The following is a description of a gene set: species: Homo sapiens from publication He P, Lim K, Sun D, Pett JP, Jeng Q, Polanski K, Dong Z, Bolt L, Richardson L, Mamanova L, Dabrowska M, Wilbrey-Clark A, Madissoon E, Tuong ZK, Dann E, Suo C, Goh I, Yoshida M, Nikolić MZ, Janes SM, He X, Barker RA, Teichmann SA, Marioni JC, Meyer KB, Rawlins EL (PMID 36493756) Human Gene Set: HE_LIM_SUN_FETAL_LUNG_C2_MEGAKARYOCYTE Megakaryocyte, and this is the list of marker genes: UNC45A, STRN4, IGF2BP2, LRRC8B, CLIC4, TMEM41A, CYB5R1, SLC35D1 (solute carrier family 35 member D1), RAB38, GSE1, ABLIM1 (actin binding LIM protein 1), AP5S1, PRKAA1, FRMD3, CST7, TUBGCP4, ING5, NBEAL2, AATK, KLHL5, KIAA0232, UNC13D, HEMGN, VPS37B, GP6, SERPINH1, SMIM3 (NCBI Gene Id 85027), APPL2 (NCBI Gene Id 55198), BANK1, SERPINE2 (NCBI Gene Id 5270), SLC22A17 (solute carrier family 22 member 17), SLC37A1, MSANTD3, GET1, ATP2A3, SNCA, FURIN, MAD2L1BP, IFI27L1, C11orf21, ZBTB16, TAL1, SACM1L, TUBA4A, MAFG, PPM1A, EPOR, PNMA1, RTN2, NFIB, EMILIN1, KIFC3, GTF3C5, EGF, MINDY1, MLC1, CD226, WASF1, ESAM, SMTN, ARHGAP6, TLK1 (NCBI Gene Id 9874), GFOD1, DGKI, GRK4, INPP5B, PELO, IGF1R, HPGD, ALAD (aminolevulinate dehydratase), SIRT3 (NCBI Gene Id 23410), PDE3A, LYPLAL1, ARMC8, PGM1, DENND4C, TREML1, AGBL5, DGKD, DBN1, SLC18A2, MINDY2, GP5, STK17A, ZNF185, CASP6, BET1L, RHD, PANX1, TMEM164 (transmembrane protein 164), CASS4, NLRX1, TRAPPC2, PROS1, EGLN3, HPSE, HGD, RAB30 (NCBI Gene Id 27314), INAFM2, TBC1D20, DNAJC16, AKT2 (NCBI Gene Id 208), KALRN, CXCL3, LIMA1, NCKAP1, ASB8, KLHDC8B, CPNE5, ARL15, MPL, RECQL5, TSPAN15, RHBDD1, AXIN1, BLZF1, ROCK2, MOB1B, RHOF, CTTN, PF4, CLCN4, PTGIR, PPBP, TBC1D25, NLRC5, PHTF1, PKP2, IRAG1, GATA2, CLU, ARG2, USP20, PPM1L, PDGFC, GSAP, PTK7, MTFR1L, RAB13, PDGFA, ACVR1, CLCN3, C1orf116 (chromosome 1 open reading frame 116), GAS2L1, SPHK1, TNIK, CTNNAL1, IRAK2, ATP2C1, ZNF664, CD69, MCU, GTPBP2 (NCBI Gene Id 54676), ATE1, VWA5A, LRRC32, TXNL4B, ICAM2, STRADB, MPP7, CKAP5, INPP4B, H2BC11, SLC7A5, SPATS2, GRK5, RCHY1, TSPAN32, MBOAT2, EML2, NLK, LRP12, FHOD1, PHTF2, TSC22D1, UBE2O, GADD45A, ORAI2, ZNF431, FADS1 (NCBI Gene Id 3992), EPHX2 (NCBI Gene Id 2053), KCNE3, LDLRAP1, FAR2, ZFYVE21, SPTBN1 (spectrin beta, non-erythrocytic 1), PROSER2, LINC01089, LRRC8D, CDK17, PKIG, CRKL, SLC39A4, CALU, MPIG6B, SLFN14, PTCRA, TBPL1 (TATA-box binding protein like 1), TMEM64, NHLRC2, GNB5 (NCBI Gene Id 82962), MCTP2, ITGA6, PF4V1, MMRN1, ZCCHC17, C1orf198, CDKN2D, TMEM45A, SFI1, F11R, RAB33A, SMIM1, HTRA2, CD40LG, EFNB2, ST3GAL3, HEXIM1, GTDC1, SLC7A1, ADIPOR2, TMEM263, SELP, SLC44A2, TVP23B, NOL4L, CCL5, TRIP10, DOLPP1, HNRNPLL, PFKP, PRR7, RNF8 (NCBI Gene Id 9025), KLHL6, ARHGAP10, FHL2, MYO18A, GJA4, CALCOCO1, LINC00989, SPARC, KIFAP3, BLTP1, RNF11, RGS3, PHKA2, RAB37, XK, PBX1, TDRP, TUBA8, ATOSB, FN3K, GNG11, MTHFD2L, C12orf75 (NCBI Gene Id 387882), MARCHF3, CCR4 (C-C motif chemokine receptor 4), ACAD8, NT5C3A, WIPI1, FAH, LMNA, GRTP1, TMEM40, RAB27B (NCBI Gene Id 5874), TJP2, EHD3, FKBP1B, NFATC1, NAE1, PRKAR2B, VKORC1L1 (NCBI Gene Id 154807), CA2, GOLGA2, PADI4, NEXN, HTATIP2, CALD1, YES1, LAPTM4B, LURAP1L, DAAM1, ALOX12, ATG9A, TIMP3 (NCBI Gene Id 7078), PLCH1, DNAJB2, SLC50A1, RCL1, MGLL, PDE5A, CTDSPL, SPRY1, TIMM22, MEST, NPAT, TSPOAP1-AS1, CLEC1B, PTP4A3, RNF24, AHCTF1, UBL4A, PTGS1, BEX3, TCEA2, ZMYND8, GRAP2, INSIG2, CGRRF1, HBD, GUCY1B1, CENPT, ECE1, CCRL2, RNF34 (NCBI Gene Id 96268), TTC5, ACRBP, MYCT1, CENPV, UBASH3B, GMPR, TMED8, CNST, SEPTIN11, E2F3, TMSB4Y, PLA2G12A, SLAIN2, C3orf52, ANXA3 (NCBI Gene Id 306), HYI, ATP8A1 (NCBI Gene Id 10396), RIT1, PGRMC1, YOD1, ITFG1, RGS6, MARCHF2, TECPR2, SLC9A1, SLX4, FAM83D, LY6G6F, TMEM91, SIAE, HBQ1, TMEM140, SAMD14, TEC, SIAH2, TMEM163, USP47, SRSF8, STK26, CYREN, PHETA2, TSPAN18, PIK3R6, NDST1, ANO6, RAB3C, EFHC2, CDK2, SESTD1, XPNPEP1, PKHD1L1, UXS1, HIPK2, PRICKLE1, PAPSS2, AFAP1, THBS1, CXCL2, CTSW, NID1, PEX3, WRNIP1, MAP4K5, BTN3A2, MDM1, IGSF10, TOM1L2, CASP3, VPS26B, DHCR7, SLC35D3, RAMP1, TC2N, SCFD2, PLOD2, SWI5 (NCBI Gene Id 375757), ANKRD9, PLPP5, TSPAN13, MEIS1, CCDC28B, PRKCQ, ENDOD1, TENT5C, KCTD20, PYCR2, STOM, ZNF778, P2RY1, FAM234A, GOLT1B, SPIN2B, MITF, ADORA2B, SMOX, TUBB1, VANGL1, LCN2, KLF9, CA13, SYTL4, MTURN, PPP1R14A, MAP4K2, LXN, ORAI1, CARMIL1, LRBA, TRPC6, TBXA2R, INKA2, EPS15L1, RHAG, TNFAIP8L1, GCLM, MAP1A, P2RX1, TRAFD1, H2BC7, ARL6IP6, CFAP45, ABHD4, AQP10, STXBP5, ARHGEF12, ABCC4, LIN54, CKB, LINC01003, UBE2C, GABRE, ZC3HAV1L, MAP3K5, ELOVL7, TMEM63A, DGKG, ANKRD28, LIPH, ADCY6, RHOBTB1, CLDN5, PEAR1, ZGLP1, FAM157C, GATA1, MAP1LC3A, ISOC1, TRIM13, LRRFIP2, PAPSS1, PDLIM1, CD82, ARHGEF3, STX1A, MACIR, TMEM87B, LTBP1 (NCBI Gene Id 4052), SPX, H3C10, SLC10A3, INKA1, SLC44A1, ENTREP3, EXOC3L2, NET1, ANKRD33B, ITGB3, MMD, ITGA2B, KCTD10, OSBP2, BCL2L1, SERPINE1, H2BC4, FYN, VPS13A, ADAT2, SMYD3, CLIP2, CMAS, HEXIM2, GCSAML, AGPAT1, OXCT1, RDH11, TMEM185A, TESPA1 (NCBI Gene Id 9840), TCTA, PYGB, DNM3, ZNF33A, TNNC2, HSDL1, MBTD1, TMEM63B (NCBI Gene Id 55362), MOB3C, E2F6, PDGFB, SMIM5, MADD, WDR44, CMTM5, PDIA5, MIR4435-2HG, COMTD1, GNAZ, SAV1, FBXW9, ENO2, CCDC68, GP9, TSPAN9, ISCA1, CMTM2, STIM1, MICU1, EPDR1, CTNS, DHRS7B, ABLIM3, ASH2L, IFT57, ANGPT1 (NCBI Gene Id 284), SLA2, MYL9, TFPI, TTC7B, MLH3, TTC33, TCEAL9, VAPB, TPM1, MAST4, LY6G5C, ICA1, F2R, ABCC3, FAM30A, FAXDC2, PRKAR1B, BET1, VIM-AS1 (VIM antisense RNA 1), B3GNT2, SPTB, RASGRP3, BBC3, ARHGAP21, COL24A1, MED12L, ACTR3B, MFAP3L, CHST12, NPRL3, PPP1R35, MINPP1 (multiple inositol-polyphosphate phosphatase 1), LAT, SLMAP, VAMP7, C19orf33, PSRC1, PIK3CB, CATSPER1, MAN2A2, SSX2IP, DCAKD, LCA5, RASA3, PIM1, PRKD2, MYOM1, TANGO2, TRAPPC3L, RUFY1, CDIP1, HERC1, ZFAND2B, PARD3, ZNF175, NCK2, SLC39A3, TGFB1I1, OPHN1, MEG3, PRTFDC1, PCSK6, BIVM, FHL1, SLC30A5, COQ2 (NCBI Gene Id 27235), NFE2, TSPAN2, TPM2, RBM38, EGLN2, XYLT2, OTUD5 (OTU deubiquitinase 5), LINC02284, DMTN, INF2, TNNI3, NCKIPSD, PTPN12, PCYOX1L, SCYL2, TRIM58, LANCL3, RIPOR3, CDC37L1, PDZD8, SRC, SH3BGRL2, LGALS12, MFSD2B, PRUNE1, FNBP1L, ASAP2, CAVIN2, ANK1, LGALSL, PTK2, GADD45G, PLEKHF2, TRIM24, GFI1B, CRAT, TTC39B, HBG1, COPS4, PLAG1, MGAT4B, ABCA7, PDK1, DCLRE1A, SSBP2, MAVS, GPD2, CR1L, CDC14B, NSMCE3, ABHD16A, TNS1, XIRP2, MYLK, SLC24A3, PDE4D, GP1BA, VCF1, ATG4D, MAPK6, NRGN, STON2, UTY, PDLIM7, PTGER3, MIGA2, CSTPP1, ACCS, FUT8, DENND2C, KIAA0513, F2RL3, CD9 (NCBI Gene Id 928), SDC4, TNFSF4, TWSG1, NECTIN2, WFDC1, NT5M, SUSD1, TM6SF1, CD109, EVA1C, FADS2, CD151, C2orf88, RBPMS2, EFNB1, RAB11FIP3